The following is a description of a gene set: from publication Li Z, Li T, Yates ME, Wu Y, Ferber A, Chen L, Brown DD, Carroll JS, Sikora MJ, Tseng GC, Oesterreich S, Lee AV (PMID 37272757) As one of the most successful cancer therapeutic targets, estrogen receptor-alpha (ER/ESR1) has been extensively studied over the past few decades. Sequencing technological advances have enabled genome-wide analysis of ER action. However, comparison of individual studies is limited by different experimental designs, and few meta-analyses are available. Here, by ingesting large amount of E2-related transcriptomic data sets in breast cancer cell lines, we identified gene expression changes across 66 RNA-seq and 80 microarray experiments based upon the E2-induced fold change in gene expression. We derived the percentile of gene expression change for each individual gene normalized to all genes expression changes within each experiment, and filtered out genes that were detected in less than 80% of experiments. We derived consistency-to-inducibility maps consisting of genes across 146 comparisons. We identified 65 upregulated and 22 downregulated genes that were enriched in top 10% percentile of altered genes and consistent across at least 50% of comparisons as the meta estrogene up and down regulation signatures. studied in species Homo sapiens Human Gene Set: LI_ESTROGENE_META_E2_RESPONSE_UP High confident estrogen up-regulated genes in breast cancer cells merged from 146 NGS datasets-based comparisons (10% topmost up-regulated genes and consistent in at least 50% comparisons)., and this is the list of marker genes: H19, MYB, C6orf141, ADORA1 (adenosine A1 receptor), KCNK5, RAPGEFL1, TMPRSS3, CELSR2, CISH, SLC7A5, FKBP4, IGFBP4, RBP7, PTGES, DOK7, GREB1, MICB, ELOVL2, FOS, SGK1, NPY1R, NHERF1, MYC, FHL2, SFXN2, HSPB8, SIAH2, CXCL12, SGK3 (serum/glucocorticoid regulated kinase family member 3), PMAIP1, ADRA2A, RBM24, SLC22A5, SLC47A1, TPBG, AMZ1, NRIP1, RET, ZNF703, FMN1, TFF1, TPD52L1, CA12, EGR3, AREG, PGR, KRT13 (NCBI Gene Id 3860), NOS1AP, CCN5, PPIF, RERG, C1orf226, C5AR2, FOXC1, RAB31, IL17RB, NEIL2, PDZK1, OLFM1, STC2, RASGRP1, PKIB (cAMP-dependent protein kinase inhibitor beta), SEC14L2, MYBL1, HEY2